The following is a description of a gene set: An mRNA destabilization process in which one or more RNA-binding proteins associate with the 3'-untranslated region (UTR) of an mRNA. species: Homo sapiens Human Gene Set: GOBP_3_UTR_MEDIATED_MRNA_DESTABILIZATION, and this is the list of marker genes: CPEB3 (NCBI Gene Id 22849), RC3H1, TARDBP, PLEKHN1, DHX36, DND1, UPF1, HNRNPD, MOV10, ZC3H12D, ZFP36L1, TRIM71, PUM2, KHSRP, ZC3H12A, ZFP36, ZFP36L2, PUM1, RBM24